Given this list of marker genes ALCAM, ULBP2, CSPG4BP, GOLGA6L2, PDPN, TXK, LRRC3, OSER1-DT, MED12L, ISG20, IDO1, FZD10, ENPP2, RHPN1-AS1, DNAJC13, HMGN3-AS1, PRSS23, EPSTI1, MCOLN2, LINC01165, CFAP206, APH1A, PGAP1 (post-GPI attachment to proteins inositol deacylase 1), LTA (lymphotoxin alpha), SCML1, IFI44L, SPSB2, P2RY14, MT4, KCNMB3, KIAA1586, PCDHGA10, NFE2L3, RAPGEF2, IRF7, PLAAT4, MAP1LC3A, TCF7, SOD2, CCL11, SLC25A28, CCDC33, LINC00895, TXNL4B, ZDHHC23, OTOGL, GBP1, SLC35F1, KAT2B, EMP1, NEURL2, KIFAP3, RNF215, MICA, SSTR3, KCNA10, DYRK3, ICOS, IL2RA, GIMAP4, IL12RB2, CHMP5, TRIM22, ANK3, CBLN4, TNFSF13B, RIPOR1, ZNF831, ITGA10, DOCK3, DHTKD1, F2RL1, POLR2M, ODR4, CD2, HELB, GBP5, DHRS9, BCL2L14, IL2, CDKN1A, SIRT1, C6orf141, GCSAM, IL18RAP, LINC01587, SLAMF1, SNORA78, SP140, SERPINB11, G0S2, VSX1, TAB2, ZBTB32, GIMAP5, LTB, SPMIP6, TRAT1, LINC00290, STAT1, KLF1, GRK3, IRF8, RBP1, LY96, ALPK1, SSBP3-AS1, CCDC191, SNHG28, GDNF, SERTAD4BP, CST9L, MAP3K8, SNHG15, SLC44A1 (NCBI Gene Id 63942), LPAR6, TRAF3, IFI16, PASK, ATP4B, GUCY1B1, CCDC158, ORM1, PYHIN1 (pyrin and HIN domain family member 1), CHST15, SAMD4B, PDE4B, BST2, TSSK3, AGFG1, ATF3, PIGQ, CLASRP, SLC41A2, RDX, OAS1, ADAMTS6, DNAJC12, AVPR1B, ZBTB3, LAP3, CAMSAP2, TSC22D1, FGF4, IFNG, PF4, CARINH, CNN1, MUC1, SLC27A2, C10orf71, WARS1, IQGAP2 (NCBI Gene Id 10788), USP46-DT, LMNTD1, PARP9, GRK5, MASTL, SIGLECL1, SLC39A13 (solute carrier family 39 member 13), PIK3R5, GPR107, GNRHR, MAPK3, IFI30, PLAT, LAMP3, SMG5, ENSG00000124835, ANXA2, TMEM140, LMO4, GIMAP7 (GTPase, IMAP family member 7), CHST2, PTCHD1, VPS50, MAP4K4, ZFYVE26, PHF11, BPIFA1, HERC5, SLA, TUB (TUB bipartite transcription factor), SOCS2, KSR1, CCL20, DUSP16, PCYT1A, CAPN3, ITGB3, IFI44, PARP14, MX1, FAS, RXRG, here is a description of the gene set: Human Gene Set: GSE17974_IL4_AND_ANTI_IL12_VS_UNTREATED_48H_ACT_CD4_TCELL_DN Genes down-regulated in comparison of CD4 T cells treated with IL4 and anti-IL12 at 48 h versus the untreated cells at 48 h. species: Homo sapiens from publication Elo LL, Järvenpää H, Tuomela S, Raghav S, Ahlfors H, Laurila K, Gupta B, Lund RJ, Tahvanainen J, Hawkins RD, Oresic M, Lähdesmäki H, Rasool O, Rao KV, Aittokallio T, Lahesmaa R (PMID 20620947) The aim of this dataset was to study in detail the transcription kinetics initiated by cytokine IL-4 in early differentiation of Th2 cells.